Given this list of marker genes ALOX5, CD2AP, BCHE, IGF2R, CCAR1, SORL1, CACYBP, APP, TUBB, PLAAT1, PTGES, here is a description of the gene set: Human Gene Set: GOCC_NUCLEAR_ENVELOPE_LUMEN The region between the two lipid bilayers of the nuclear envelope; 20-40 nm wide. species: Homo sapiens